The following is a description of a gene set: Genes down-regulated in MEF and REF cells (mouse and rat fibroblasts) but not in TIG3/T cells (human lung fibroblasts expressing TERT) by co-expression of the SV40 early region and the activated HRAS (H-RasV12). Normal human diploid fibroblasts (HDFs) are refractory to oncogene-mediated transformations in vitro, compared with rodent fibroblasts. As successful oncogene-mediated transformations of normal HDFs have been reported using the human telomerase catalytic subunit, it has been considered that telomerase activity contributes to the species-specific transformability. However, these transformed HDFs are much less malignant compared with those of rodent cells, suggesting the existence of undefined mechanisms that render HDFs resistant to malignant transformation. Here, cDNA microarray analysis identified caveolin-1 as one of the possible cellular factors involved in such mechanisms. The mitogen-activated protein kinases (MAPK) pathway downregulates Caveolin-1 in rodent fibroblasts, transformed by coexpression of the SV40 early region and activated H-Ras. In contrast, the coexpression of these two oncogenes in HDFs failed to reduce the expression level of Caveolin-1. These results strongly suggest the presence of critical differences in events following the phosphorylation of ERK during the activation process of the MAPK signaling pathway between human and rodent cells, as the ERK protein was similarly phosphorylated in both systems. Furthermore, the small interfering RNA-mediated suppression of Caveolin-1 facilitated the oncogene-mediated transformation of normal HDFs, clearly indicating that the differences in the transformability between human and rodent cells are due, at least in part, to the mechanism responsible for the resistance to Ras-induced Caveolin-1 downregulation in HDFs. species: Mus musculus from publication Sasai K, Kakumoto K, Hanafusa H, Akagi T (PMID 16832346) Human Gene Set: SASAI_RESISTANCE_TO_NEOPLASTIC_TRANSFROMATION, and this is the list of marker genes: MMP11, CACNB3, GJB3, ID3, FBLN5, ABCB6, IFNGR1, AMOTL2 (NCBI Gene Id 51421), TGFB3, ST3GAL5, JUNB, P3H1, ADAMTS1, BGN, SELENOP (selenoprotein P), LTBP2 (latent transforming growth factor beta binding protein 2), TNFRSF11B, SDC2, CDKN2C, FBN1, VLDLR, COL1A1, CEBPD, QSOX1, EDN1, PCOLCE (procollagen C-endopeptidase enhancer), PDGFRB, APP, COL5A3, SLC16A7, CXCL12, PLOD2, COL5A2, LAMB2 (laminin subunit beta 2), DDR1, FSTL1, GBP2, TAGLN, TGFB1I1, ID4, IL1RL1, IRF1, CSRP1, CCN5, ATP1B1, FBLN2, CCN2, IL6ST (NCBI Gene Id 3572), RGS10, TNFRSF1A